The following is a description of a gene set: species: Mus musculus Mouse Gene Set: GOBP_NON_CANONICAL_NF_KAPPAB_SIGNAL_TRANSDUCTION An intracellular signaling cassette characterized by the NIK-dependent processing and activation of NF-kappaB. Begins with activation of the NF-kappaB-inducing kinase (NIK), which in turn phosphorylates and activates IkappaB kinase alpha (IKKalpha). IKKalpha phosphorylates the NF-kappa B2 protein (p100) leading to p100 processing and release of an active NF-kappaB (p52). The non-canonical NF-kappaB signaling pathway is generally activated by ligands of the TNF receptor superfamily, including lymphotoxin beta (LTB), CD40, OX40, RANK, TWEAK and B cell-activating factor (BAFF)., and this is the list of marker genes: Tlr4, Cyld, Sash1, Laptm5, Spi1, Tnf, Trem2, D1Pas1, Rassf2, Nlrc3, Amfr, Smpd3, Tlr3, Rtkn2, Hdac7, Rps3, Ccl19-ps6, Litaf, Trip6, Calr, Nlrp3, Edaradd, Sphk1, Trim15, Tcim, Rel, Trim55, Ndufc2, Rc3h1, Phb2, App, Il18 (NCBI Gene Id 16173), Akt1, Adgrg3, Ptp4a3, Actn4, Il18r1, Terf2ip, Zc3h12a, Pdcd4, Relb, Tlr7, C1qtnf4, Nfkb1, Ppm1b, Cd86, Trim60, Rc3h2, Trim44, Nfkbia, Havcr2, Prdx1, Grem1, Phb1, Rela, Pycard, Chi3l1, Chuk, Hmgb1, Akip1, Zfp91, Il1b, Btrc, Vcp, Bcl10, Tnfsf14, Capn1, Ccn3, Trim56, Cops8 (NCBI Gene Id 98184), Letmd1, Bcl3, Nfkb2, Rbck1, Tek, Cpne1, Edar, Ank3, Lrrc19, Ccl19-ps4, Nr3c2, Eif2ak2, Map3k14, Ifi35, Nmi, Birc2, Ccl19, Tlr2, Ccl19-ps1, Ager, Ptpn22, Traf2, Nod1, Ago1, Crebbp, Traf6, Nol3, Adissp, Adipor1, Birc3, Trim26, Ccl19-ps3, Uaca, Tlr1, Nlrp12, Ago3, Ripk3, Ccl19-ps5, Ppm1a, Mkrn2, Card10, Ddx3x, Egfr, Tab3, Map3k7, Nod2, Tab1, C1qtnf3 (NCBI Gene Id 81799), Ripk1, Lime1, Tab2, Tlr9, Edn1, Fbxw11, Eda